Given this list of marker genes CTSD, SERPINA3, ITIH1, ANXA4, IGFBP7, P4HA1, SERPING1, SDC1, MFGE8, SFRP4, SLPI, SPON1 (NCBI Gene Id 84806), S100A11, TIMP1, PLOD2, FBLN5, AGRN, ITIH2, AEBP1, COL16A1, CTSB, EFEMP2, MXRA5, CILP, HPX, TIMP2, VCAN, PCOLCE, COL5A1, LMAN1, C1QB (NCBI Gene Id 713), CTHRC1, C1QC, ANXA6, FBLN1 (NCBI Gene Id 2192), SERPINF1, PXDN, KNG1, THBS1, FGL2, MGP, FBLN2, NPNT, CLEC3B, COL4A4, COMP, TNC, S100A13, P3H1, F13A1, THBS2, PLOD3, FMOD, LTBP2, ANXA5, S100A6, F2, HRG, SERPINA1, here is a description of the gene set: from publication Naba A, Pearce OMT, Del Rosario A, Ma D, Ding H, Rajeeve V, Cutillas PR, Balkwill FR, Hynes RO (PMID 28675934) species: Homo sapiens Human Gene Set: NABA_MATRISOME_HGSOC_OMENTAL_METASTASIS Patient samples were kindly donated by women with high-grade serous ovarian cancer (HGSOC). We optimized protocols to solubilize ECM proteins from normal or tumor tissues, digest the proteins into peptides, analyze ECM peptides by mass spectrometry, and interpret the mass spectrometric data. Using LC-MS/MS, we analyzed ECM-enriched samples of disease-free omentum from patients with non-metastatic ovarian cancer and HGSOC-derived omental metastasis samples. A second critical step of the approach was the identification and annotation of the ECM components, or matrisome, in large proteomic data sets. The curation of this signature utilized crude ECM extracts rather than urea-soluable extracts. This gene set lists the matrisome proteins detected in significantly differential abundance in omentum metastases from high grade serous ovarian cancer (HGSOC) compared to normal omentum. Matrisome proteins detected in significantly different abundance in omentum metastases from high grade serous ovarian cancer (HGSOC) compared to normal omentum.